Given this list of marker genes Nuak2, Gm10538, Tnni1, Gm23939, Tnnt2 (troponin T2, cardiac), Inava, Gm33994, Zfp281, 1700113B19Rik, Kif14, Gm4204, Gm16083, Csrp1, Ptprv, Golt1a, Nr5a2, Eif2d, Lgr6, Myog, Mapkapk2, Gm8790, Ctse (cathepsin E), Aspm, Mir135b, Camsap2, 4933436E23Rik, Gm24086, Mgat4f, Gm29487, Gm17781, Rabif, Gm25549, Gm29695, Kif21b, Phlda3, Ascl5, 1700006P03Rik, Zp3r (NCBI Gene Id 98633), Elf3, Slc41a1, Lad1, Gm29630, Slc45a3, Dyrk3, Kiss1, Cdk18, Gm28441, Gm15850, Mir6903, Pfkfb2, Arl8a, Ptpn7 (NCBI Gene Id 320139), Platr22, Cd55os, Gpr25, Mfsd4a, Dennd1b, Avpr1b, Btg2, 9230116N13Rik, Lhx9, Sox13, D130019J16Rik, Prelp, Tmcc2, Atp6v1g3, Cd55, Gm15790, Gm19705, AA986860, Rab7b, Pm20d1, Gm7241, Il10, Ppp1r12b, Gm29257, Rnpep, Gm5833, Mybph, Rab29, Atp2b4, Gm8596, Il24, Zbtb41, Ddx59, Klhdc8a, Fcmr, Gm18553, Mgat4e, Gm28500, Gm28609, Plekha6, Lmod1, Gm29485, Gm29428, Ptprc, Il19, Gm29718, Gm16304, 1700019P21Rik, Gm17796, Cyb5r1, Ipo9, Gm28856, Yod1, Ikbke, Etnk2, Il20, Chi3l1, Tmem81, Gm28857, Gm15454, A130071D04Rik, Fcamr, Gm22609, Pigr, Gm25609, Slc26a9, Gm18970, Gm16305, Gm34816, F730311O21Rik, Fmod, Gm22727, Gpr37l1, C4bp, Lemd1, Zbed6, Ppp1r15b, Ube2t, Rassf5, Srgap2, Gm23623, Mroh3, Gm8618, Adipor1, Tent2-ps2, Timm17a, Adora1, 6030442K20Rik, 4930596I21Rik, 2610012C04Rik, Igfn1, Tuba5-ps, Kdm5b, Crb1, Gm28913 (NCBI Gene Id 102631674), Gm15675, Nfasc, Mir181b-1, Gm29486, Optc, Tmem183a, Cd55b, Mif-ps1, Fam72a, Nek7, Gm37120 (predicted gene, 37120), Mir181a-1, Mdm4, Gm19461, Cntn2, 2310009B15Rik, Ppfia4, Elk4, Gm23056, Pkp1 (NCBI Gene Id 98390), Gm15848, Lax1, A430034D21Rik, Gm4793, Tmem9, Gm25612, Gm23534, Zc3h11a, Nucks1, Mir181a-1hg, Snrpe, Gm10535, Gm10537 (predicted gene 10537), Chit1, Gm3933, Shisa4, Gm8532, Dstyk, Rpl31-ps9, A130050O07Rik, Thsd7b, Rbbp5, Pik3c2b, Lrrn2, 4933409D19Rik, Syt2, Klhl12, Mir1231, Nav1, Rnu7-ps3, Ren1, Cacna1s, here is a description of the gene set: Mouse Gene Set: chr1E4 species: Mus musculus